The following is a description of a gene set: Human Gene Set: GSE22886_NAIVE_CD4_TCELL_VS_NKCELL_UP species: Homo sapiens Genes up-regulated in comparison of naive CD4 T cells versus unstimulated NK cells. from publication Abbas AR, Baldwin D, Ma Y, Ouyang W, Gurney A, Martin F, Fong S, van Lookeren Campagne M, Godowski P, Williams PM, Chan AC, Clark HF (PMID 15789058) Immune cell-specific expression is one indication of the importance of a gene's role in the immune response. In order to identify such patterns, we set out to broadly profile gene expression in a variety of immune cells., and this is the list of marker genes: TNFSF8, GRPR, GSN-AS1, RPUSD2, PRKCA, TNFRSF10D, GCFC2, RPS6KA2, CD28, EEF2, SNU13, TMEM243, BIRC7, GABBR1, KCTD17, KCNQ1, ADARB1, CD5, TJP3, MORC4, IRS4, TTC19, LIPE, MALT1, GRAP, GRSF1, OSBP2, PIDD1, BAG3, UBASH3A, NOL6, PRKRA, HSPB1, CD4, TRAV8-3, BCAT2, ABT1, EPHB4, ID3, UNC119, SLC25A37 (solute carrier family 25 member 37), FAM171A1, INSL3, CCNE1, EIF3D (eukaryotic translation initiation factor 3 subunit D), PABPC4, SLC16A10, SFRP5, TLE2 (NCBI Gene Id 7089), SLC48A1, TRMT1, RERE, MACROH2A2, FCER2, IL23A, TFB1M (transcription factor B1, mitochondrial), EPHB6, JUNB, RPS6, MEST, GPSM3 (G protein signaling modulator 3), CNN2, MAST4, CBR3, DAGLA, SNRNP40, PEMT, MCF2L, CCNC, DNAJB1, ANGPT2, SMU1, PCP4, MSL3, STK17B, LOXL1, GNB5 (NCBI Gene Id 82962), GFRA3 (NCBI Gene Id 2676), DPP4, HTR3B, THAP7, LRCH4, OBSCN, KAT8, KIF5C, ZNF580, CSGALNACT1, ARL2BP, HBZ, NELL2, RSPH14, ATP1A1, TSPYL2, TAF6, NR4A2, RCE1, TMEM30B, PPP1CC, TTN, TBC1D4, AKAP1, MAP4K4, WWP1, PLEKHM2, CDR2, LEF1, GPR162, SF3A2, AIP, GAMT, VIPR1, MISP, R3HDM4, DLGAP4, ICOS, TRAC, DGKA, SUN1, HBS1L, PBXIP1, CRMP1, MAL, FABP6, KCNC3, FCGRT, FOXO1, SEMA3B, SARAF, NCK2, DAP3, LZTS3, PHF1, COPZ1, PLK3, RETREG1, ETNK2, CHMP7, C8orf33, MPP1, MAP4K2, SCMH1, PKIA, SERINC5, LY86, NFATC1, RGS14, CAD, PASK, SIRPG, AP1G2, MCUB, TBX2, INF2, VTCN1, SRP14, TOM1, SMYD5, AQP3, CD40LG, IZUMO4, INPP4B, LYPD3, NOSIP, FLT3LG, SUSD4, CAMK4, TUBBP5, TNS2, TNFRSF10B, FBLN5, CASP6, ZNF771, STMN3, BCLAF1, SERPINA2, RAB40C, ARTN, APOA4, CD27, GNG11 (NCBI Gene Id 2791), CACNA1I, LTB, CALM3, SUGCT, RAPGEFL1, HDHD3, SRRM1, SEC31B, HMGA1, GGT1, PAFAH1B3, TNFRSF25, GAS2L1, ADTRP, ZNF467, PLEKHB1